The following is a description of a gene set: Human Gene Set: GOBP_REGULATION_OF_TRANSCRIPTION_FROM_RNA_POLYMERASE_II_PROMOTER_BY_GLUCOSE studied in species Homo sapiens Any process involving glucose that modulates the frequency, rate or extent of transcription from an RNA polymerase II promoter., and this is the list of marker genes: USF1, OGT, USF2, MLXIPL, KAT2B